Given this list of marker genes KCNJ2, CHGA (NCBI Gene Id 1113), PDE4B, CAMK2D, ATP1A2, RGS2, P2RX4, ATP2A2, GSTM2, PDE4D, ATP1A1, PIK3CA, ATP1B1, PLN, HRC, GSN, SLC8A1, here is a description of the gene set: species: Homo sapiens The process in which the extent of cardiac muscle contraction is reduced. Human Gene Set: GOBP_RELAXATION_OF_CARDIAC_MUSCLE